Given this list of marker genes DNAAF1, ADAR, CARD19, BCL2A1, RAB5A, ZNFX1, NCOA7, SGPP2, ADPRS, KYNU, IFI35, DDX60L, PI4K2B, TMEM140, DUSP5, MFN1, MELK, SLC31A2, BTG2, TNFAIP2, KIAA0040, PLAT, ATF5, SFT2D2, SERPING1, PIM3, IL1B, ACSL1, PLEK, TMEFF1, PSMB9, MAP3K13, RECK, LRRFIP2, APOBEC3A, SP110, WTAP, ETV7, DYNLT1, KLF9, ZNF189, NT5C3A, IFI44, NFKBIA, IFIT5 (NCBI Gene Id 24138), IRF7, NEMP1, SLC41A2, EPOP, STAP1, NLRC5, MIR155HG, CCL4, CASP7, UBXN2A, HERC5, ATF7, NFKBIZ, NAMPT (nicotinamide phosphoribosyltransferase), FAM135A, MIA, CD274 (NCBI Gene Id 29126), TNFSF15, SMCO4, MYD88, SRGAP2, TMEM268, FBXO7, CCL5, OAS1, OAS3, IFIH1, INO80D, IRF9, IL7, CFLAR, ZNG1A, IDO1, RHEBL1, LINC01588, USP18, PMAIP1, GBP1, UBE2Z, AMD1, RARG, TNC, CCL1, SOD2, TRIM26, PARP14, MVB12A, MT2A, TXNL4B, CXCL11, WARS1, BST2, UBE2N, NXN, DNAJB4, BRIP1, IFIT1, PPP2R2A, EIF2AK2, PNPT1, IL7R, CMPK2, UBE2L6 (NCBI Gene Id 9246), HESX1, ENSG00000289047, TFEC, ST7-AS1, RUNX3, TARS1, MAK, NEURL3, IRF1 (NCBI Gene Id 96501), SHFL, MT1X, CNTLN, BATF2, NUB1, CSRP2, GMPR (NCBI Gene Id 2766), STARD5, PML, IL15, CARINH, MX2, ATF3, ELL2, IFITM1, CATSPERZ, OASL, CKAP4, GRB10, FSD1L, NUPR1, TDRD7, ARHGAP22, GCH1, PLA2G4A, EEF1AKMT3, IFI6, TRAF1, OAS2, DNAI3, CNP, POGLUT1, SAMD4A, MIR3945HG, RAB12, GBP5 (NCBI Gene Id 115362), TRAFD1, ISG15, GBP2, BCL2L14, RTP4, IFIT3, LILRB1, MICB, TNFSF10, SLAMF7, TTC39B, TYW5, FUT4, APOL6, XAF1, MIER1, TRIM21, NFAT5, NINJ1, IFIT2, PPM1K (protein phosphatase, Mg2+/Mn2+ dependent 1K), MSC, TNFAIP6, IFI44L, NR4A3, EXT1, IRF2, GPD2, DTX3L, PTGER4, COQ10B, KMO, NBN, EPSTI1 (epithelial stromal interaction 1), HSH2D, NABP1 (nucleic acid binding protein 1), RIGI, ISG20, PIWIL4, IFI27, MCOLN2, ZC3H12C, CD80, NECTIN3, IFNA2 (NCBI Gene Id 8005), PARP9, here is a description of the gene set: Human Gene Set: GSE14000_UNSTIM_VS_4H_LPS_DC_DN studied in species Homo sapiens Dendritic cells (DCs) are the sentinels of the mammalian immune system and they undergo a complex maturation process mediated by activation upon pathogen detection. Recent studies described the analysis of activated DCs by transcriptional profiling, but translation regulation was never taken in account. Therefore, the nature of the mRNAs being translated at various stages of DC activation was determined with the help of translational profiling, which is the sucrose gradient fractionation of polysomal-bound mRNAs combined to microarrays analysis. Total and polysomal-bound mRNA populations were compared in immature (0h) and LPS-stimulated (4h and 16h) human monocyte-derived DCs with the help of Affymetrix microarrays. Biostatistical analysis indicated that 296 mRNA molecules are translationally regulated during DC-activation. The most abundant biological process among the regulated mRNAs was protein biosynthesis, indicating the existence of a negative feedback loop regulating translation. Interestingly, a cluster of 17 ribosomal proteins were part of the regulated mRNAs, indicating that translation may be fine-tuned by particular components of the translational machinery. Our observations highlight the importance of translation regulation during the immune response, and may favour the identification of novel gene clusters or protein networks relevant for immunity. Our study also provides information on the possible absence of correlation between gene expression and real protein production in DCs. Genes down-regulated in comparison of dendritic cells (DC) before and 4 h after LPS (TLR4 agonist) stimulation. from publication Ceppi M, Clavarino G, Gatti E, Schmidt EK, de Gassart A, Blankenship D, Ogola G, Banchereau J, Chaussabel D, Pierre P (PMID 19943945)